The following is a description of a gene set: Human Gene Set: REACTOME_NUCLEOTIDE_EXCISION_REPAIR species: Homo sapiens Nucleotide Excision Repair, and this is the list of marker genes: POLD1, COPS3, POLE2, UBB, POLE, LIG1, CUL4B, TCEA1, POLD2, PIAS1, GTF2H1, POLK (NCBI Gene Id 51426), PRPF19, MCRS1, PPIE, NFRKB, PARP1, CUL4A, USP45, POLR2G, ACTL6A, POLD3, POLR2J (RNA polymerase II subunit J), YY1, TFPT, GTF2H3, POLR2H, RAD23A, INO80E, USP7, COPS6, INO80B, SUMO1, POLR2D, MNAT1, UBC, POLR2E, UBE2N, PARP2 (NCBI Gene Id 10038), ELL, ISY1, ERCC3, UBE2V2, POLR2K, COPS5, ERCC6, RNF111, DDB1, DDB2, ACTR5, ERCC8, RFC4, POLR2C, GTF2H5, RPA3, RFC1, PIAS3, POLR2A, RFC5, POLR2F, XAB2, XPC (NCBI Gene Id 7508), RPA1, PCNA, CETN2, CDK7, UBA52, INO80, SUMO2, GTF2H4, CCNH, COPS2, RAD23B, POLR2B, CHD1L, RBX1, POLD4, UVSSA, LIG3, ACTB, UBE2I, POLE3, ACTR8, POLR2L, AQR, ERCC4, COPS7B, COPS8, GTF2H2, RFC3, POLE4, XRCC1, ERCC1, ERCC2, XPA, COPS7A, ERCC5, COPS4, INO80D, GPS1, ZNF830, SUMO3, POLR2I, RUVBL1, RFC2, INO80C, RPA2, RPS27A